The following is a description of a gene set: species: Homo sapiens Docosahexaenoic acid (DHA), a major ω-3 polyunsaturated fatty acid (PUFA) found in fish oil is the source of protectins (PDs), one of the specialized proresolving mediators (SPMs) that show potent anti-inflammatory and pro-resolving actions. The switch from synthesis of pro-inflammatory eicosanoids, such as the prostaglandins and the thromboxanes, to the pro-resolving lipoxins, resolvins and protectins, occurs via induction of the 15-lipoxygenase enzyme.<br><br>Protectin, identified as (N)PD1 (N signifies neuroprotectin when produced in neural tissues) is derived from DHA through the actions of 15-lipoxygenase then enzymatic hydrolysis. Aspirin can also trigger the formation of epimeric protectin (AT-PD1). An additional protectin (DX) is formed through the sequential actions of two lipoxygenase reactions. The biosynthesis of these protectins is described here (Balas & Durand 2016, Balas et al. 2014, Serhan et al. 2014, Serhan et al. 2015). Reactome Pathway: Biosynthesis of protectins part of: Biosynthesis of DHA-derived SPMs, and this is the list of marker genes: CYP1A2, ALOX15, LTA4H, CYP1A1